The following is a description of a gene set: Human Gene Set: GSE39556_UNTREATED_VS_3H_POLYIC_INJ_MOUSE_CD8A_DC_DN The injection of the pathogen-associated molecular pattern Polyinosinic-polycytidylic acid (poly(I:C)) leads to the activation of various immune cells, including dendritic cells (DCs) and Natural Killer (NK) cells. This activation is due to different innate cytokines produced early after injection, in particular IFN-I. The objective of the study was to compare the pattern of expression of IFN-I stimulated genes between DC and NK cells. The project focused on a specific subset of conventional DC, CD8a DC, which responsiveness to IFN-I determines the capacity to activate CD8 T cells by cross-presentation of exogenous antigens. To identify the responses to IFN-I selectively induced in CD8a+ DC, we compared their gene expression profile to that of NK cells, using gene chips, before and after poly(I:C) stimulation. species: Homo sapiens Genes down-regulated in CD8A dendritic cells: untreated versus poly(IC). from publication Baranek T, Manh TP, Alexandre Y, Maqbool MA, Cabeza JZ, Tomasello E, Crozat K, Bessou G, Zucchini N, Robbins SH, Vivier E, Kalinke U, Ferrier P, Dalod M (PMID 23084923), and this is the list of marker genes: TSC22D4, AP3S1, SLC2A5, SATB1 (SATB homeobox 1), GSN, STARD3, SNX17, KLF10, SIAH2 (NCBI Gene Id 6478), ARAP2, IFNA2, PECAM1, SPINK2, ADA, GUCY1A1, ETS2, MAPK8IP3, GNS, LRIG1 (NCBI Gene Id 26018), IL2RG, PXDN, PSD3, PIP4K2B, NDRG1, TNFSF4, CD99, RAB13, HOXA9, SOCS2, SERPING1, GRB14, PPM1F, ANXA7, TKT, ALOX5AP, UBA7, REEP5, ITPR1, USP15, GNG11, SEC63, PRMT2, PHF21A, GBP1, DEXI, AHCYL2, AFF1, PLSCR1, WASHC4, SMARCD2, MEF2C (myocyte enhancer factor 2C), FHIT, TSPAN7, HCP5, ZMIZ1, DYRK3, ACSL1, PNISR, SERINC5, ARL6IP5, FAN1, SCARF1 (NCBI Gene Id 8578), MXI1, ACTN1, SERPINI1, BEX4, BCL11A, FCMR, IMPDH1, AK1, KLHL9, AREL1, BMI1, ITGA5, GLS, ST3GAL6, PPP3CC, GPR171, TRAPPC6A, VAV1, LILRA2, ADH1A (alcohol dehydrogenase 1A (class I), alpha polypeptide), PTGER2, H2BC12, TMCC1, ARMCX2, LCP2, IQGAP2, AUH, HLX, H3C10, DEPP1, ANKRD17, H2BC21, LYZ, EDEM1, FOXO3, NFYA, UBL3, MPPED2, COMT, TBXA2R, PFN2, CD96, RALGAPA1, SERPINB6, CERS6, STAM, ERG, SV2A, LTB, LILRB2, ATP6V0E2, SYT11, KCNS3, GAB2, SYNGR1, HMHB1, EFCAB14 (EF-hand calcium binding domain 14), LST1, OS9 (NCBI Gene Id 10956), APP, PDE9A, FYN, PRMT1, PDE4B, LRRC15, JADE2, RAG1, ZZZ3, TRAF3IP2, TMEM87A, NRIP1, RGL1, CHST15, PBXIP1, KDSR, LIPA, CDS2, H2AC6, PCMTD2, OR7A5, SENP6, IGFBP7, DMXL2, GJA5, LAPTM4A, IFI44, P2RY14 (NCBI Gene Id 9934), LMO2, PLXNB2, LRRC41, MLXIP, SORL1, GADD45A, ASB9, SPTA1, FBLN5, HOXA10, RECK, TRANK1, CREG1, FUT4, THEMIS2, BAZ2B, LGALS3BP, AKAP12, MAP4K4, TLE1 (NCBI Gene Id 7088), CACNB3, STX3, AMPD2, ABLIM1, KLF7, F13A1, SMAD1, HHEX, PTPRE, AIF1, SLC31A1, RETREG1 (reticulophagy regulator 1), ARHGAP25, LIPT1, RSAD2, NR3C1, H2BC5, SRSF8, CKMT2, ZFYVE16, TUBA4A, CALCOCO2, MYLK, ATP2B4 (NCBI Gene Id 54594), GNAQ, ARHGEF17, WWP1, GYPC, MMRN1, TNFAIP3, PRKCI (protein kinase C iota)